Given this list of marker genes Sycp1, Cdk2, Rad51c, Dazap1, Mei1, Cpeb1, Rarb, Bcl2l2 (NCBI Gene Id 12050), Fus, Mlh3, Fkbp6, Atm, Ubb, Dmc1, H2ax (H2A.X variant histone), Ip6k1, Bmp8a, Limk2, Sgo2a, Stx2, Ubr2, Bcl2l1, Lmna, Dmrt1, Gal3st1, Hspa2, Slc25a4, H3f3a, Bcl2, Cks2, Sohlh1, Brca2, Bub1b (NCBI Gene Id 99239), Pms2, Morc1, Msh5, Mybl1, Ybx3, Smc1b, Hsf1, Fanca, Ube2b, Hsf2, Sycp3, Egr4, Exo1, Tex11, Rara, Tex15, Btrc, Msh4, Psmc3ip, Ercc1, Cstf2t, Mlh1 (NCBI Gene Id 68687), Bcl6, Ccna1, Sycp2, Piwil2, Trip13, Tert, Bsg, Tex14, Siah1a, Cnot7, Pafah1b2 (platelet-activating factor acetylhydrolase, isoform 1b, subunit 2), Bag6 (NCBI Gene Id 80605), Ovol1, Gnpat, Spo11, Rec8, Piwil4, here is a description of the gene set: Reproduction is required for the survival of all mammalian species, and thousands of essential 'sex' genes are conserved through evolution. Basic research helps to define these genes and the mechanisms responsible for the development, function and regulation of the male and female reproductive systems. However, many infertile couples continue to be labeled with the diagnosis of idiopathic infertility or given descriptive diagnoses that do not provide a cause for their defect. For other individuals with a known etiology, effective cures are lacking, although their infertility is often bypassed with assisted reproductive technologies (ART), some accompanied by safety or ethical concerns. Certainly, progress in the field of reproduction has been realized in the twenty-first century with advances in the understanding of the regulation of fertility, with the production of over 400 mutant mouse models with a reproductive phenotype and with the promise of regenerative gonadal stem cells. Indeed, the past six years have witnessed a virtual explosion in the identification of gene mutations or polymorphisms that cause or are linked to human infertility. Translation of these findings to the clinic remains slow, however, as do new methods to diagnose and treat infertile couples. Additionally, new approaches to contraception remain elusive. Nevertheless, the basic and clinical advances in the understanding of the molecular controls of reproduction are impressive and will ultimately improve patient care. Mouse Gene Set: MATZUK_SPERMATOCYTE from publication Matzuk MM, Lamb DJ (PMID 18989307) studied in species Mus musculus Genes important for spermatocyte, based on mouse models with male reproductive defects.